Given this list of marker genes AGR2, LIN28B, ORAI1, IL7R, HEATR3, DCLRE1C, OTULIN, POLA1 (NCBI Gene Id 5422), SLC51A, KMT5B, ITGB2, TFRC, REL, RYR3 (ryanodine receptor 3), TERT (telomerase reverse transcriptase), CHD7, CLMP, CYP27A1, NSUN2, SLC51B, ATP6AP1, HACE1, WIPF1, LIG4, CASP8, LRBA, CARMIL2, C4B, VPS45, ANTXR2, PIK3R1, ADNP, SREBF1, ETHE1, CARD11, ADA, SON, DNASE2, IPO8, CD3G, SAMD9, PGM1, RFXANK, PHOX2B, STX3, TKFC, PERCC1, PIK3CD, IRF2BP2, ATP5F1A, CD3D, SAA1, FOXP3, IKBKB, BTK, PKP1, ALG1, HYOU1, HEXB, B2M (beta-2-microglobulin), SKIC2, ZAP70, COG6, CCDC47, COG4, TNFRSF1A, IL6ST, LMO1, EPCAM, ITCH, FCHO1, CR2, BACH2, IDS, WAS, IL2RA, SLC10A2, USP7, MGME1, SLC39A4, PPP2R5D, IGKC, ATP7A, ALK, SLC19A1, MAP3K14, RNF113A, RMRP, MTTP, DOCK2, IKBKG, TCF3, ATM, MYCN (MYCN proto-oncogene, bHLH transcription factor), IL21R, ASAH1, MVK, SLC35C1, CARD8, NFKBIA, TOM1, RAG2, JAK3, MADD, RBCK1, RAG1, ERCC2, NBN, IDUA, IL2RG, GUCY2C, SLC5A1, IGHM (immunoglobulin heavy constant mu), here is a description of the gene set: Human Gene Set: HP_CHRONIC_DIARRHEA Chronic diarrhea studied in species Homo sapiens The presence of chronic diarrhea, which is usually taken to mean diarrhea that has persisted for over 4 weeks.